Given this list of marker genes Plagl2, Soat1, Soat2, Abca7, Mfsd2a, Ces1g, Fech, Dgat1, Ces1d, Lcat, Arf1, Apoe, Mttp, Cideb, Nr1h2, Lpcat3, Apoa2 (apolipoprotein A-II), Apoa1, Acsl3, Apom, Abca1, here is a description of the gene set: Mouse Gene Set: GOBP_PLASMA_LIPOPROTEIN_PARTICLE_ASSEMBLY The non-covalent aggregation and arrangement of proteins and lipids to form a plasma lipoprotein particle. species: Mus musculus